Given this list of marker genes IL2RG, SOCS3, SOX2, IGHG4, TP53, BCL2L1 (BCL2 like 1), HSPA8, MMP2, OPRM1, IL1B, ITGB2, LIF, IL12A, RHOU, IL4R, FOS, HSP90B1, CD36, IL13, FASLG, TWIST1, ITGAM, COL1A2, POU2F1, BIRC5, JAK2, IL13RA2, ANXA1, IL6, IL6R, VIM, CCL11, ICAM1, TGFB1, FN1, IL12B, F13A1, IL23R, ITGAX, MMP3, IGHE, IL18, BATF, IL23A (NCBI Gene Id 51561), STAT3 (signal transducer and activator of transcription 3), HSP90AA1, MYC, OSM (oncostatin M), ITGB1, SAA1, TIMP1 (NCBI Gene Id 7076), ALOX5, IRF4, LAMA5, ALOX15, HGF, AKT1, TNF, TNFRSF1B, PIK3R1, LCN2, PIM1, MMP1, FCER2, VCAM1, HMOX1, IGHG1, FOXO3, CCL2, GATA3, SOCS5, S1PR1, IL13RA1, HIF1A, BCL6, CEBPD, CXCL8, MUC1, BCL2, RORC, FSCN1, IL10, FOXO1, MCL1, JUNB, MAOA, NDN, OPRD1, CCND1 (NCBI Gene Id 893), ZEB1, SOCS1, JAK1, IL17A, JAK3, MMP9, FGF2, STAT1, IL17F, LBP, VEGFA, CDKN1A, TYK2, NANOG (NCBI Gene Id 92937), STAT6, IL4, IL1A, CCL22, RORA, NOS2, POMC, PTGS2, here is a description of the gene set: studied in species Homo sapiens Human Gene Set: REACTOME_INTERLEUKIN_4_AND_INTERLEUKIN_13_SIGNALING Interleukin-4 and Interleukin-13 signaling